The following is a description of a gene set: Reactome Pathway: Signaling by NTRKs electronically inferred by orthology from the curated human pathway This event has been computationally inferred from an event that has been demonstrated in another species.<p>The inference is based on the homology mapping from PANTHER. Briefly, reactions for which all involved PhysicalEntities (in input, output and catalyst) have a mapped orthologue/paralogue (for complexes at least 75% of components must have a mapping) are inferred to the other species. part of: Signaling by Receptor Tyrosine Kinases studied in species Mus musculus, and this is the list of marker genes: Grb2, Pik3cb, Ppp2r5d, Hras, Mapk7, Fyn, Kidins220, Ngf, Dusp6, Pcsk5, Dusp7, Ntf5, Ap2a1, Shc2, Shc1, Irs1, Mapk3, Crk, Shc3, Ap2m1, Ppp2r1b, Rps6ka5, Egr2, Map2k1, Bdnf, Pik3r2, Map2k2, Ap2s1, Frs2, Vrk3, Mapk11, Irs2, Ralgds, Mapk14, Ap2b1, Sgk1